Given this list of marker genes TGFB1, TOLLIP (NCBI Gene Id 54472), FPR2, TLR1, ALOX12, HLA-DRB3, CXCL10, SHH, CSRP1, ICAM1 (intercellular adhesion molecule 1), CRTC3, CD7, CX3CR1, ARID1B (NCBI Gene Id 645070), PIK3CD, CD47, ASTL, BCL3, AKT1, VSIG4, P2RX7, PGLYRP3, SLAMF6, TTBK1, LRFN5, DGKE, IRGM, VAMP3, PLA2G10 (phospholipase A2 group X), APP, P2RY12, SLC15A4, LRRK2, SIRPG, HMGB3 (NCBI Gene Id 3149), GSN, MAPK14, ZP2, HHLA2, ACTL6B (NCBI Gene Id 51412), VAV3, HLX, LCN10, GPR65, ATF2, CARD11, CSK, PLA2G3, CST7, BST2, PTCRA, YY1, DUSP10, CD3D, FANCD2, IL18R1, KLRC4-KLRK1, PIK3CG, PKN1, IL10, DNAJB9, PLA2G4A, PBRM1, CCL21, TNFRSF4, LAG3, TMEM131L, CTLA4, GPR18, TSPAN9, EXOSC3, SIRPB1, FCRL1, LCK, APBB1IP, DGKB, CD86, KMT5B, JAML, PDPN, CD8B, FGL2, STXBP1, TRDC, ITPR3, LILRB4, TREML1, CEACAM1, SOCS1, B2M, STX4, GLI2, PTPRJ, ULBP3, SLAMF1, MIR185, CLU, SH2D2A, NPR2, PSEN1, RC3H2, IFNW1, KAT7, IL4R, TNFRSF9, HYAL2, ATAD5, AQP8, SMARCA2, FOXP3, NDRG1, SNX6, WNT1, TNFRSF21, SHLD1, DOCK11, MALT1, PDIA3, TPST2, SEMA6D, TREML2, SNAP23, CLECL1P, CD48, CD44, LEF1, SELENOK, KLRC1, RGCC, IFNA14, CYP26B1, RAB44, IL2RA, TGFBR1, PLCZ1, BCL6, BCL11B, SIT1, LIG4, TWSG1, ZNF683, TMX1, SOCS3, ERBB2, ITPRIPL1, ACTA2, CD226, GNAS, F11R, SH3KBP1, CD19, CD33, GBA1, NRARP, IL31RA, CR2, ZAP70 (NCBI Gene Id 7535), PRELID1, CD274, OPA1, ACTN1, GPER1, BRD4, IFNB1, SMAD7 (NCBI Gene Id 4092), CCL19, LGALS8, NAGLU, SCGB1A1, AMBRA1, HLA-DQA2, SLURP1, DGKG, TBK1, CNR2, CLC, GCLM, F2, FKBP1B, LILRB1, SOX4, MMP8, INHA, SKAP2, YWHAG (tyrosine 3-monooxygenase/tryptophan 5-monooxygenase activation protein gamma), CCR2, PIK3R6, DTX1, PMS2, ZFP36L2, SLC39A7, CXADR, SMARCB1, DLG5, SRC, DPP4, IGFBP2, F2RL3, EMILIN2, KIR3DS1, NFKB2, NFATC2, PTGDS, PPP2R3C, PRR7, HTR2A, BMPER, ATM, CLIC1, PRAM1, TBX21, HLA-E, DUSP3, FLT3LG, TLR9, ADORA2A, IGHM, RUNX3 (RUNX family transcription factor 3), CX3CL1, TAFA3, BRD7, PLPP6, TPD52, ST3GAL1, PHB2, ITGA4, MILR1, NFIL3 (nuclear factor, interleukin 3 regulated), SPN, JAK3, RHBDD3 (NCBI Gene Id 25807), FGB, CMTM7, BMP4, GATA1, HLA-A, TREX1, MAD1L1, IFNGR1, VSIR, FOXF1, CD2AP, RAB27A, BAX, SPTA1, CLEC12A, ULBP2, PRDM1, EBI3, SLC11A1, PDIA2 (NCBI Gene Id 95435), F2RL2, DDRGK1 (DDRGK domain containing 1), SVEP1, ZC3H8, NHEJ1, TNFAIP3, LILRA5, LGALS1, ZP3, SNX27, GP6, ICOS, AP3B1, KLRD1, TNFRSF13C, DCAF1, IL18RAP, MAP3K8, CD69, SPI1, TCIM, CD24, CDH26, ULK3, PRNP, UBD, SLC4A2, KRT2 (keratin 2), MEF2C, ADGRG3, PAG1, VCL (vinculin), CLCF1, PRKCE, FAM114A1, SH2D1B, IL15, SOCS5, PLCB1, EPO, PLAT, LAT2, ZBTB46, KLRC3, LGALS9C, VPS33B, BATF, PLA2G5 (NCBI Gene Id 5322), PTPRC, ADAM8, ERCC1, MYD88, METAP1, PGLYRP1, TGFBR2, TCF3, HHEX, CXCL8, NFATC3, LMBR1L, EFNB3, ITFG2, CCL2, TBC1D10C, RAG2, NFAM1, ZBTB1, MTOR, SAA1, CXCR5, RARA, SOX11, HLA-DQA1, PRKG1, IL2RG, BRAF, UNG, MIR128-1, KLRF1, CD46, NFKBID, PDGFB, EMP2, UNC13D, CASP8, SHLD3, KAT2A, FAM76B, ADORA2B, IFNG (interferon gamma), LRP1, DLL4, CXCL6, GCLC, TNFSF13, SPHK2, STAT3, ANXA1, NCKAP1L, RASAL3, CD8A, IKZF1, VCAM1, SLAMF8, RAP2B, MIF, CHRNB2, HRG, POLM, LTBR, IFNL1, METTL3, PRKCD, AP3D1, GP9, HLA-DRA, CR1, DCAF15, FNIP1 (folliculin interacting protein 1), STK11, PRKDC, SDC4, TYRO3, EXO1, TFRC, THBD, NPY, SMO, RORC, DGKQ, CAPN3, PAX5 (paired box 5), CCR6, RABGEF1 (NCBI Gene Id 27342), ACTL6A, IL20RB, CDK6, GRP, GRN, NLRP3, IL6R, SH3RF1, CD3G, BTN2A2, TSPAN32, CELA2A, IGBP1, FCHO1, SPHK1, ULBP1, HLA-DOA (major histocompatibility complex, class II, DO alpha), SANBR, FZD5, RPL22, IL27RA, TLR3, SLAMF7, TNFSF4, FZD9, LGALS9B, CD40LG, NLRC3, GPS2, THEMIS2, RPS3, ABL1, CD81, FES, PLA2G2D, STXBP3, CD3E, NLRP5 (NCBI Gene Id 126206), BPI, DROSHA, ADGRF5, RASGRP1, CD247, KAT5, CD1C, PURA (purine rich element binding protein A), SELP, LMO4, PLA2G2F (phospholipase A2 group IIF), PRKAR1A, SPINK5, TXLNA, HSPH1, SMARCE1, ADGRG1 (NCBI Gene Id 9624), JMJD6, TOP2B (DNA topoisomerase II beta), IL7R (interleukin 7 receptor), BLOC1S6, BLOC1S4, KIT, CLEC4D, IL27, CCR7, DNASE1, PCYT1A, GAL, PDGFA, WNT10B, HMCES, CD83, SELPLG, IFNE (interferon epsilon), AHR, CTSL, IL33, ZNHIT1, MYB, NECTIN2, CAV1, AIF1, FUNDC2, NBN, CEACAM21, SHPK, EP300, F2RL1, KMT2A (NCBI Gene Id 79951), IL17A, FN1, P2RX4, DGKK, WNT5A, HMGB1, SYK, MIR21, PSMB11, PRKCQ, ZBTB16, CD55, TNFRSF13B, LST1, ALKBH5, DGKH, CAMK4, FERRY3, SRF, GPR15LG, GPR183, SPACA3, SLC7A1, EZH2, IRF4, TCF7, NCK1, FYN, CD27, CYLD, VAMP7, SWAP70, CD40, CD9, SOD1, IDO1, GP1BB, MYL9, SOCS6, CD209, CD300LF, RBPJ, ZEB2, TNFRSF14, CCL5 (NCBI Gene Id 8147), EPHB1, NCSTN, CHGA, GATA3, CHD7, HDAC4, ARID2, BTK, IL11, PTPN22, SLC25A5, HSPA12A, IL18, C1GALT1C1, CTSC, NCR1, ACTB, KMT2E, SIRPA, ZMIZ1, DYSF, DOCK10, PRKCB, HELLS, DHPS, NCAPH2, WNT4, MDM2, STAT5A, WDFY4, IL12B, FZD8, CD177, LY9, KITLG, HLA-DRB1, STK39, CD200, FCAR, XRCC6, STAP1, TRAF2, PPP3CA, SASH3, LCP2, IFNA16, PDPK1, DOCK2, DLL1, SLC39A10, MIR92A1, NOD2, CSF2, SLC6A4, CLEC4A, EGR3 (NCBI Gene Id 1960), CGAS, MIR145, P2RX1, LFNG, IFNA8, MRGPRX2, GAS6, HLA-DMB, CRLF2, TRAF6, ATP7A, ANXA3, CD180, PKNOX1 (PBX/knotted 1 homeobox 1), NKAP, HFE, WNK4, WNT3A, TSLP, MARCHF7, CD160, ZNF3, TRAC, SMAD4, CEBPA, DAPL1, IMPDH2, SHB, LIPA, PHF10, MAPK8IP1, ARG2, LOXL3, NR5A2, TNF, PTPN6, DNASE1L3, SHLD2, MICA, PTPN2, IRS2 (insulin receptor substrate 2), CHRNA4, SLC18A2, FCER2, S100A12, NOTCH2, CPLX2, ARG1, TNFSF18 (NCBI Gene Id 8995), RPL13A, IRF1 (interferon regulatory factor 1), PBX1, CD320, BANK1, DGKA, LILRB2, FIBP, DHRS2, TARM1, BTN3A1, RABL3, IFNA21 (NCBI Gene Id 3452), FCGR2B, BATF3, XBP1, TNFSF8 (TNF superfamily member 8), PRDX2, FOSL2, INPP5D, IL7, DDR2, BAD, PLEK, FER, MSH2, CBFB, HLA-DMA, RASSF5, IL9, CTPS1, CYRIB, FLOT2, XCL1, TIRAP, PF4, NDFIP1, KLF5, TMEM98, LCP1, LAX1, CD37, NKX2-3 (NCBI Gene Id 53631), TP53, FGG, KCNK18 (NCBI Gene Id 338567), RIF1, PPIA, CSF1, MCUB, P2RY1, RUNX2, MERTK, IL21R, RSAD2, FZD7, IGF2, ZC3H12A, ATG5, MEN1, RC3H1, SOS2, PJA2, RHOA, BLOC1S3, RAG1 (NCBI Gene Id 5896), ZP4, BCR, PATZ1, GKN2, RUNX1 (NCBI Gene Id 861), IL12RB1, IL2, FLT3, SAMSN1, GLI3, SNCA, ASCL2, GP5, HLA-DPA1, DGKI, NMI, INHBA, VTCN1, SOX15, RNF41, PREX1, CRTAM, SERPINE2, IFNA1, IL21, STAT4, SMAD3, ONECUT1, DOCK8, TNFSF14, IFNA2, EFNB1 (NCBI Gene Id 1947), BCL2, USP44, ADAMTS18, LBP, SOX13, VWF, CORO1A, MICB, IGF1, CTSG, FOXO3, FCER1A, GATA2 (NCBI Gene Id 84724), SMARCD1, PRKCZ, ZBTB7A, IL23R, DCLRE1C, IGHE, LAT, C17orf99, RIPK3, EDN2, IL15RA, TNFSF11, RBX1, BLNK, PRMT5, CEBPG, LYN, ENTPD2, F2R (coagulation factor II thrombin receptor), IFNA5, RPS6KA1, SBNO2 (NCBI Gene Id 22904), SLAMF9, PTPRE, HES1, IL6, ITGB6, PLCG2, GNRH1, S100A13, FGF10, SUPT6H, GPNMB, VAMP2, AKAP12, ELF4 (E74 like ETS transcription factor 4), TLN1, FCER1G, POU2AF1, FKBP1A, CLEC4E, ITGB8, GNAQ, CNTF, CD6, GPAM, TNFAIP8L2, TNIP2, LGALS3 (NCBI Gene Id 81625), CCDC88B, MMP14, APLF, ZEB1, APOE, TRGC1, HDAC9, PRF1, MIR130A, BTNL2, TMEM106A, IL1RL2, GPR89A, CYGB, FGA, LGALS9, SLC39A6, DLG1, CD84, NR1H3, IFNA6, CD244, IL13, HBB, IFNA10, PDGFRA, FOXP1, CD300A, SUCNR1, ADAM17, PSMB10, ITGB3, IFNA7 (interferon alpha 7), PHF14, MFSD2B, BID, VAMP8, XIRP1, IL36B, ZP1, AZU1, PDCD1, PLCL2, C1QA, IL12A, LY6D, CD151, LYL1, FZD6, ITM2A, PIBF1, IL16, PLA2G2A, HPRT1, KPNA1, MIR125A, ITGAM, IRF2BP2, ITGAL, AKAP17A, BAK1, DUSP22, MIR17HG, MEGF10, CD93, MYO18A, SMARCA4, MIR181B1 (NCBI Gene Id 406955), CBL, JAG2, DGKZ, IL23A, BST1, SMARCC2, HLA-DRB5 (NCBI Gene Id 731247), GJD4, JUND, GAB2, NOS3, SLC7A11, TLR6, CASP3, FERMT3, CLEC4G, IRF8, HLA-DRB4, ADAM10, PRKAA1, PIK3CB, HDAC5, LEPR, VAV1, RELB, LRRC32, LAMP1, SMARCD2, PAWR, DNAJA3, GAPT (NCBI Gene Id 202309), ID2, SYVN1, IL1B, FGR, KDELR1, PGLYRP2, LAPTM5, GLMN, HOXA9, BATF2, CRACR2A, VAV2, ADAMTS13, JUNB, STARD7, STOML2, IL4, IL1RL1, LRRC8A, CD4, TNFSF13B, JAK2, SFTPD, KLRC2 (NCBI Gene Id 3822), DDOST, LMO1, C3, CCND3, AICDA, NKG7, MSH6, CD38, DGKD, ITK, RAB29, IL17RA, FBXO7, CXCR2, TSC1, CDKN1A, PCID2, RNF168, PPP3CB, JAK1, EIF2AK4, ENPP3, AKIRIN2, MPL, LILRA2, TYK2, NR4A1, SNX4, HAVCR2, PAXIP1, MAFB, GP1BA, PIK3R3, BAG6, NFKBIZ, GIT1, FCRL5, STXBP2, FUT7, TRAF3IP2, ABL2, THEMIS, PLXNA1, TMEM229B, CEBPB (CCAAT enhancer binding protein beta), GNA13, TACR1, PTK2B, CLEC7A, ARMC5, PTPN11, HSPB1, C5AR1, CBLB, TAC1, HLA-DQB2, SOS1, MYH9, NEDD4 (NCBI Gene Id 4734), ITGB1, NTRK1, AP1G1, SCNN1B, BCL10, SPIB, STAT5B, ADAM9, ZNF335, BMI1, TREM2, MIR181C, TICAM1, COL3A1, SEMA4A, RNF8, THY1, TESPA1, PDP2, MT1G, GPR89B, HSH2D, CCL3, AIRE, ENTPD7, RHOH, KIF13B, CADM1, CDH17, PELI1, ZBTB7B, UFL1, MYL12A, COMP, CDKN2A, PDCD1LG2, LDLR, MMRN1, AZI2, PRDX1, PTGER4, DCSTAMP, IL6ST, CD79B, SMARCD3, CTNNB1, CD80, FCGR3A, SFRP1, TAOK3, TUSC2, GPR137B, TNFRSF1B, GRB2, ZFPM1, DCAF12, ADRA2A, KMT5C, SLC46A2, RAC2, WAS, MAD2L2 (NCBI Gene Id 10459), CD74, LEP, ILK, KLRF2, MR1, IFNA4, ZFP36L1, ADA, NR1D1, TNFSF9, EOMES (eomesodermin), EXOSC6, IL5, BTLA, INS, MIR142, SH2B3, IFI35, MS4A1, IFNA17, FBXO38, CLEC2B, FANCA, NCR3, SLA2, TIGIT, ITGB2, HAVCR1, MYC, HLA-DOB, UBASH3B, IHH, MDK, RASA3, ADRA2C, SH2D1A, SART1, CUL4A, PRKCA, CD276, PRLR, CD22, FLNA, PYCARD, HLA-F, MLH1, EMILIN1, FADD (Fas associated via death domain), ICOSLG, IL13RA2, TRBC1, MIR30B, TRBC2, ACTG1, CAMP, IL4I1 (NCBI Gene Id 259307), IL1A, TYROBP, CALHM2, MZB1, TMIGD2, RORA, STAT6, PLSCR1, PCK1, ARID1A, CD79A, CD28, IKZF3, JUN, HLA-DPB1, PIK3R2, AGER, MFNG, VNN1, SP3, SOX12, NCR3LG1, EGR1, C1QTNF1, KLF6, CLPTM1, SYT11, KCNJ8, IFNGR2, TEC, FCRL3, SMARCC1, THBS1, WNT7A, HLA-DQB1, TCIRG1, KLHL22, MFHAS1, TLR4 (NCBI Gene Id 7099, toll like receptor 4), PEAR1, PSG9, NSD2, ADRA2B, ILDR2, PHB1, HLA-G, BRD2, NEDD9, RIPOR2, PIK3R1, ENTPD1, EFNB2, PIK3CA, AXL, FOXJ1, CD1D, TOX, CD5, MIR19A, MNDA, CD70, HSPD1, FOXN1, CD2, YES1, MSN, KLRK1, NR4A3, ITCH, WBP2NL (WBP2 N-terminal like), KARS1, PARP3, SCN11A, IFNK, TP53BP1, NCK2, FGL1, TUBB1, ITPKB, IMPDH1, MAPT, EPHB2, PNP, CLNK, KLHL25, PRG3, EDN1, SCRIB, RIPK2 (receptor interacting serine/threonine kinase 2), CCR9, PTGDR, GBF1, MIR27A, ADGRE2, here is a description of the gene set: A multicellular organismal process by which exposure to an activating factor such as a cellular or soluble ligand results in a change in the morphology or behavior of a cell. species: Homo sapiens Human Gene Set: GOBP_CELL_ACTIVATION